The following is a description of a gene set: studied in species Homo sapiens Genes predicted to be targets of miRBase v22 microRNA hsa-miR-5187-3p in miRDB v6.0 with MirTarget v4 prediction scores > 80 (high confidence targets). Human Gene Set: MIR5187_3P from publication Chen Y, Wang X (PMID 31504780), and this is the list of marker genes: DDHD2, ACBD3, NFKBID, KLF3, CNGB1, RAB27A, JCHAIN, ZDBF2, SDHC, XKR4, MAGEB2, PACSIN2, MBNL2, LYSET, DIPK2A, TMEM87A, RIMS2, STARD9, GIMAP6, OSM, LIFR, DMXL2 (NCBI Gene Id 23312), TRIM38, STRN, ADAM22, ARHGEF33, SH3TC2, ACP1, MED19, ZNF19, RNF141, TXLNB, FAM110C, MSRB3, CP, UBE2R2 (ubiquitin conjugating enzyme E2 R2), MAGEB4, ZWINT, ZDHHC20, ARHGEF12, EAF2, TGFBR1, PPP3R1, CLOCK, PGM3, GLIPR1, CCN4, UFM1, ZSCAN21 (zinc finger and SCAN domain containing 21), SUCO, OR51E1, HIPK3, UBR3, HS3ST5, TCF7L1, NDEL1, PICALM, TMTC1, PCDH19 (NCBI Gene Id 89774), UBFD1, DCUN1D5, NRG1, MOBP, LIMD1, DOK6, CHMP5, COX11, PTCD3, CBLN2, FBXO11, PSMC6, KCNE5, DOLK, KSR1, GSKIP, PTGES3, PDCD6IP (NCBI Gene Id 245794), OAZ1, GPATCH2L, OGFRL1, KCNK2, DMXL1, ANKRD33B, EYA4, ANKRD34B, SMIM13, TRUB1, KIAA0232, FSIP1, VSTM2A, ABI1, SLCO3A1, ZCCHC10, UBN2, RNF20, EIF1AD, UBASH3B, ARID4A, CRELD2 (cysteine rich with EGF like domains 2)